Given this list of marker genes TBX3, NFIB, TP53, PTCH1, MIR320D2, ZFP36L1, HOXA3 (NCBI Gene Id 3200), TP63, SHOX2, SOX11, RUNX2, PBX1, TGFBR2, NOTCH1, FGF4, N4BP2L2 (NEDD4 binding protein 2 like 2), MIR16-1, FGF9, TERT, PTPRC, OVOL2, FGF8, GLI3, HNRNPU (heterogeneous nuclear ribonucleoprotein U), CCNE1 (cyclin E1), MIR93, MIR320E, MIR320D1, WNT5A, FERMT2, PRRX1, MIR320C2, THPO, RARG, CITED1, WNT10B, KDR, SHH, HMX2, RBPJ, MIR29B1, NF1, WNT1, RARB, KITLG, NF2 (NCBI Gene Id 654093), FERMT1, FGFR1, SIRT6, ACE, YAP1, MIR320B2, ELL3, KDM1A, MIR320A, WNT11, FGF10, SOX9, TGFBR1, FGF2, MIR320B1, AGO3, EIF2AK2, FBLN1, IRF6, SOX17, CEBPA, MIR222, VEGFC, OVOL1, KDF1 (keratinocyte differentiation factor 1), MIR320C1, OSR2, SOX18, KAT7, HMGA2, PDCD2, DGCR8, EPCAM, HMGB2, TGFB1, CD109, SFN, GJA1, ATXN1L, SNAI2, NR2E1 (nuclear receptor subfamily 2 group E member 1), CDKN2C, NANOG, PIM1, LTBP3, CTNNB1, TSC22D1, MIR181A2, MIR221 (NCBI Gene Id 407006), here is a description of the gene set: Human Gene Set: GOBP_REGULATION_OF_STEM_CELL_PROLIFERATION Any process that modulates the frequency, rate or extent of stem cell proliferation. A stem cell is a cell that retains the ability to divide and proliferate throughout life to provide progenitor cells that can differentiate into specialized cells. species: Homo sapiens